The following is a description of a gene set: Genes down-regulated in myeloid-derived suppressor cells from colon tumors: wildtype versus HDC knockout. species: Homo sapiens Human Gene Set: GSE23502_WT_VS_HDC_KO_MYELOID_DERIVED_SUPPRESSOR_CELL_COLON_TUMOR_DN from publication Yang XD, Ai W, Asfaha S, Bhagat G, Friedman RA, Jin G, Park H, Shykind B, Diacovo TG, Falus A, Wang TC (PMID 21170045) Differentially expressed genes of CD11b+Gr-1+ immature myeloid cells (IMCs) in the bone marrow and colonic tumor setting of histidine decarboxylase (HDC)-KO mice were examined by microarray (Affymetrix Mouse 430.2 array). Myeloid differentiation-related candidate genes were sought to be isolated and functionally studied., and this is the list of marker genes: GABRE, HOXC8, GPC5, RNF138, HSPB3, TERT (telomerase reverse transcriptase), GLI2, TSPAN7, FNIP1, CKM, DNAAF6, ATP1B4, NXPH4, PTK6, PADI3, PTGDS (NCBI Gene Id 5730), OLFM2, IMMP2L, CALN1, NR1D2, CR2, VIPR1, TMEM182 (NCBI Gene Id 130827), AGL, MOXD1, TMEM125, SLC10A2, MAP6, DBX1, RAG2, ERCC6, TROAP, CIMIP4, HOMER2, ZNF711, C2CD4C, LARGE2, ARPIN, PDCD4, ERCC4, HTR7, STARD6, SALL4, DOCK10, TCF21, C6orf141 (chromosome 6 open reading frame 141), DDX6, SCGB3A1, DTWD2, PAPOLB (poly(A) polymerase beta), SUCO, OVOL1, FKBP14, LRP1B, FRMD5, BCL2L10, DRAM2, FGF10, MORC4, MAGEL2, ARHGAP20, IFTAP, ZDHHC11, TMPRSS11F, PHOSPHO2, SNAI1, TMEM45A, TERB1, RTN4RL2, OLIG3, DUSP6, VAX1, COL5A2 (collagen type V alpha 2 chain), COBLL1, SLC7A10, CRYAA, RCVRN, RIMBP3C, ASB5, FAAH, CD1D, CORO2B, CALCRL, CDHR1, PRRT1, HTR2C, LHX6, GFPT2, PSMA8, RTL3 (retrotransposon Gag like 3), GNG2, NRG1, HSD17B3, H2BC18, ADAMTSL4, LIPN, OLFM4, GKN2, COL8A2, CYP3A43, OXGR1, KRT35, KRT26, MISFA, VAT1, CISH, ABCA6, KRT86, ADGRB3, DPH5 (diphthamide biosynthesis 5), MMP2, BFSP1, C5orf47, SLC29A4, RNF130 (ring finger protein 130), FOXP1, KY, FOXS1, KRT84, STXBP6, MGAT4C, MYOD1, NTMT2, ANG, TLCD3B, ESRRB, TRIM29, ST8SIA5 (ST8 alpha-N-acetyl-neuraminide alpha-2,8-sialyltransferase 5), EFHC2, EPHB1, RAPGEFL1, HROB, GRM4, KRT13, SNPH, GAREM2, GLRB, MICALL2, PTGS1, ARX, GBGT1, MATN3, PLA2G6, STYK1, NPL, MYO5C, TLR3, PPP1R3G, NFASC, BMI1, CCDC81, FMR1NB, PRR15L, SOX21, SCLT1, KCNJ12, CNTN3, ABCC9, BPIFC, ZP1, PRR23A, KCNK13, NKX2-5, ZDHHC17, NPY5R, CD84, SLC2A2, ACKR3, CHRNB4, BCORL1, AVPR1A, KIAA1549L, NIM1K, FXYD6, PLAU, DDO, SOX13, MDFIC, NMUR1, LRRC74A, ZNF667, MPV17L, TMEM209, MYO5B, GPR149, HRH4, TOR1AIP1, LDLRAD3, C12orf71, SP6, IRX5, RBM3, BAZ2B, MDM4, RALYL, SRRM4, IAPP, PTPRT, TBC1D9